Given this list of marker genes FEM1C, TERF2IP, RNF19B, HSPA12A, HBS1L, ZIC3, GTF2H5, MAGEC3, PUS3, CHMP5, TAX1BP1, KCNQ4, KAZALD1, SPRED2, SLCO1B1, LGALS8, DLST, SMAP1, NEUROG2, TOP1, GGNBP2, MSH6, RHOH, CCNL1, GTF2B, NDST2, FAM131B, ANGPTL4, ERH, CEP72, CCL8, SOCS3, TRAPPC4, GABRG2, SATB2, PELI1, SETD4, BRCA1, DACT1, HLX, GRIP2, LAP3, CXCL14, SCN1A, PPP6C, ZFP36, CCDC9, CRTAC1, GFM1, GOLPH3L, MAGEA6, CISH, VPS50, IFIT2, GADD45G (NCBI Gene Id 23575), ARPP21, OR2F1, CXCL10 (NCBI Gene Id 3627), PTGDR2, AMOTL2, RGS17, RPS10P5, SKP1, PPP1R3D, GADD45B, KRT14, MFAP3, PPP1R7, ELANE, C10orf88, CDON, GZMK, SRPK2, LRP5L, TWF1, IFIT5, ABCD2, ROS1, RND1, SCYL3, SAV1, VSX1, PCNX4, RBM7, CKMT2, LCP2, TMX1, MAT2B, SHFL (NCBI Gene Id 55337), GAST (gastrin), PCK1, UFC1, CEP162, CXCL11, MTNR1A, APOL6, NET1, EMC2, DGUOK, SI, ENY2, S1PR4, ZNF226, UGDH, ARHGAP33, ADRA1B, S100A11, OR1E1, SLC28A2, TSGA10, SPTLC2, STK38L, PICALM, IFIT3, TTTY14, S100A13, PLEK, GBP1, NKX2-1, DUSP6, PANK2, CACNB4, DGKQ, SOCS1, UGT2B17, CNTN6, CBR3, KCNJ2, MRPS28, BCL6, FLG, FBXL5, LGALS4 (galectin 4), ERCC3, GNG10, FGF9, BBIP1, RBX1, DRICH1, CCDC134, DDX23, CREBBP, KIF26B, DNAJC13, CDKN1A, NDUFA2, PLEKHF1, USP8, TFEC, HPSE2, AFTPH, OR2H1, PYGM, FZD5, LY96, TENT5A, PLCH2, GIMAP5, BACH1, ACTR6 (actin related protein 6), POLG, SHOC2 (NCBI Gene Id 8036), CXCL9, IRF1, GS1-600G8.3, MSRB1, RGS16, CDK2, TNKS2, PAK1, PPA1, CDC5L, PIM1, SLC10A2, CTNNBL1, ZNF267, S100A7, CLP1 (cleavage factor polyribonucleotide kinase subunit 1), POU5F1P3 (POU class 5 homeobox 1 pseudogene 3), CCNJ, PTPN13, TMUB2, B4GALT4, ACTN3, PSMB2, EZH2, FCGR1BP, PSG5, PMAIP1, TRAPPC11, GRHL2, CCL2, TUBB4A, BLK, RAB33B, ACVR1B, TRIB1, SEPHS2, here is a description of the gene set: from publication Rock RB, Hu S, Deshpande A, Munir S, May BJ, Baker CA, Peterson PK, Kapur V (PMID 16163375) species: Homo sapiens Genes down-regulated in comparison of control microglia cells versus those 1 h after stimulation with IFNG. Human Gene Set: GSE1432_CTRL_VS_IFNG_1H_MICROGLIA_DN Microglial cells are resident macrophages in the central nervous system (CNS) and play a pivotal role in the innate and adaptive immune responses against microbial infections. The immune functions of microglia are regulated by a milieu of cytokines including interferon (IFN)-gamma. We here performed a series of experiments to acertain the transcriptional profile of human fetal microglial cells at 1, 6, and 24 h after IFN-gamma treatment. Primary human microglial cells were either untreated or treated with 200u/ml IFN-gamma. Affymetrix U133A chips were utilized. Four different tissue samples (B18, O, W, and Y20) were analyzed at the three time points.